Given this list of marker genes CDH15, FOXQ1, MIR10B, SEC11A, PSMC3, MAPK1, VCL, UBA52, ILF3, PSMA2, ADAM33, DNM2, H2AB1, HDAC1, RB1, CDH4, PSMB6, TGIF2, PSMC5, UBB, FOXF1, SNAI2, SMARCA4, ACTC1, MTBP, H2BC12, VAV2, PSMA1, H2BC14, UBC, H4C1, MCRIP1, ZBTB33, PSMB3, AGO1 (NCBI Gene Id 26523), CDH13, SOX10, CDH11, MPHOSPH8, SPCS1, JAK2, NECTIN2, ZEB1, ANG, KMT5A, CSNK2A1, H2AZ2, SIRT1, ACTB, PSMB4, TNRC6A, DDOST (NCBI Gene Id 1650), TCF3, FARP2, H2BC15, H2BC11, ZNF217, H2AC4, OSTC, TIAM1, UCA1, RACK1, ZMYM2 (zinc finger MYM-type containing 2), IL6, HEYL, NECTIN3, CTSS, CANX, MIR9-1, H2BC4, CSNK2A2, STAT3, FOXA2, RBBP4, PSMD12, FOXP2, PVR, H2AC7, PKM, ARHGEF4, SP1, CDH3, PSMA5, ZEB2, JUP, MOV10, TMEM258 (NCBI Gene Id 746), CTNNB1 (catenin beta 1), CTBP2, TCF12, CDH10, TRAF7, ADRM1, PSMD14, MIR9-2, TWIST1, EPS15, H3C15 (H3 clustered histone 15), PCSK7, CDC42, H2AX, H2BC21, CDH18, PSMC2, DNTTIP1, ADAM19, NFKB1, XIAP, TNRC6C, AGO4, AGO3, SPCS3, PSMC4, RPN2, PSMA7, CTNNA1, POMT2, IL6ST, PIP5K1C, CTSL, PSMD6, KLF4, RBBP7, PSMD11, H2BC26, SNAI1, ARID1A, ZC3H12A, CADM2, PSMD8, HACE1, H2AJ, RELA, PSMD7 (NCBI Gene Id 5713), ACTG1, CSNK2B, H2AC14, HOXC8, AMOT, WT1, STRAP, KLF9, BIRC2, H2AC20, PRDM8, CDH12, PSMB2, POMT1, ACTA1, CDH19, CDH7, STT3A, CTSB, H2BC9, PSMB1, FOXJ2, IL6R, DOCK1, EED, CTBP1, CDH6, H2BC5, DAD1, SRC, SUZ12, TFAP2A, MIR9-3, H2BC13, H2BC17, MIR200C (microRNA 200c), FURIN, TNRC6B, SPCS2, CADM1, PSMA6, CDH8, GANAB, FYN, CDH9, CDH24, RPS27A, MAPK3, PSMA4, PCSK6, PSMD2, H2AC6, SEM1, NECTIN4, PSMC6, PSMC1, ACTG2, PSMB5, TLE1, TWIST2 (NCBI Gene Id 117581), AFDN, CDH1, JAK1, H2AC18, H3-3A, MDM2, ANGPTL4, SEC11C, MIR451A, RNF19B (ring finger protein 19B), EZH2, ANK3, KDM1A, PRKCSH (NCBI Gene Id 5589), OST4, RPN1, CDH5 (cadherin 5), MYC, PSMA3, PSMD3, ELMO1, CBLL1, CTNND1, CDH2, PSMB7, CADM3, H2BC12L, ARHGAP32, PSMD1, MYCN, CSNK2A3, H3C1, RAC1, HDAC2, CDH17, TYK2, ACTA2, BHLHE22, H2BC3, NECTIN1, MOGS, AGO2, PSMD13, BANP, H2BC1, here is a description of the gene set: part of: Cell-cell junction organization studied in species Homo sapiens The adherens junctions (AJ) are multiprotein complexes that promote homotypic cell adhesion in nearly all types of tissue by linking membrane and cytoskeletal components at discrete contact regions. The molecular constituents of adherens junctions form adhesive units which are organized into higher order junctional adhesions that create a zipper-like seal between adjacent cells. Junctional adhesions function in epithelial cell polarization and in the coupling of cytoskeletons in adjacent cells that allow coordinated movements. During embryonic development, AJs function in specifying adhesion between cells and contribute in the sorting of different cell types. AJs also regulate cell polarity and shape, promote cell-cell communication and help mediate contact inhibition of cell growth. This module covers transdimerization events involving AJ transmembrane proteins (cadherins and nectins). Reactome Pathway: Adherens junctions interactions